Given this list of marker genes NDUFS8, NDUFA7, NDUFA9, MT-ND5, NDUFV1 (NADH:ubiquinone oxidoreductase core subunit V1), NDUFB2, NDUFS5, MT-ND4L, ATP5MC2, NDUFB7, MT-ND3, ATP5PB (NCBI Gene Id 515), NDUFC2, ATP5MF, NDUFB1, ATP5PO, NDUFA11, ATP6V0C, NDUFS1, ATP5MJ, MT-ATP8, ATP5F1B, SDHA, ATP5F1D, ATP5MC3, NDUFS2, SDHB, ATPSCKMT, NDUFA3, NDUFV2, SDHD, MT-ND4, NDUFS4, NDUFC1, NDUFB3, NDUFB8, STOML2, NDUFA8, NDUFS3, NDUFS7, DNAJC30, NDUFB11, ATP5MK, ATP5MGL, NDUFV3, MT-ND2, NDUFA6, NDUFS6, ATP5F1E (ATP synthase F1 subunit epsilon), MT-ATP6, VPS9D1, NDUFA2, SDHC, ATP5PD, NDUFB9, ATP5MC1, ATP5F1C, MT-ND1, NDUFA5, MT-ND6, NDUFB4, ATP5F1A (ATP synthase F1 subunit alpha), ANTKMT, NDUFB5, NDUFA10, NDUFAB1, ATP5PF, ATP5IF1, NDUFA12, NDUFA13 (NADH:ubiquinone oxidoreductase subunit A13), ATP5MG, NDUFB6, NDUFB10, ATP5F1EP2, ATP5ME, NDUFA1, here is a description of the gene set: Human Gene Set: GOBP_PROTON_MOTIVE_FORCE_DRIVEN_ATP_SYNTHESIS The chemical reactions and pathways resulting in the formation of ATP driven by transport of protons across a membrane to generate an electrochemical gradient (proton-motive force). species: Homo sapiens